The following is a description of a gene set: A tall and slim body build with increased arm span to height ratio (>1.05) and a reduced upper-to-lower segment ratio (<0.85), i.e., unusually long arms and legs. The extremities as well as the hands and feet are unusually slim. studied in species Homo sapiens Human Gene Set: HP_DISPROPORTIONATE_TALL_STATURE Disproportionate tall stature, and this is the list of marker genes: COL1A2, RET, NKAP, POR, SMAD2, LOX, THSD4, HERC1, FBN1, NELFA, CHST14, UPF3B, COL2A1, FKBP14, ZNF469, LETM1, DLG4, NSD2, CTBP1, ASXL3, AKT1, BMP4, ZDHHC9, SMS, MED12, MAN2B1, ATP6V1E1, TGFBR1 (transforming growth factor beta receptor 1), CBS, ATP6V1A, TGFBR2, CPLX1, PIGG, DSE, PLOD1, MFAP5, LARS2, HPGD, SMAD3, FBN2